The following is a description of a gene set: This event has been computationally inferred from an event that has been demonstrated in another species.<p>The inference is based on the homology mapping from PANTHER. Briefly, reactions for which all involved PhysicalEntities (in input, output and catalyst) have a mapped orthologue/paralogue (for complexes at least 75% of components must have a mapping) are inferred to the other species. Reactome Pathway: Processive synthesis on the lagging strand part of: Lagging Strand Synthesis electronically inferred by orthology from the curated human pathway species: Mus musculus, and this is the list of marker genes: Pold2, Prim1, Pold4, Dna2, Rpa1, Pcna (proliferating cell nuclear antigen), Lig1, Pola2, Pola1, Pold1